Given this list of marker genes Acod1, Adam8, Neu1, C1qb, Myrip, Mmp8, Cd5l, Ms4a6d, Clec4n, Utrn, Fkbp5, Slc37a2 (NCBI Gene Id 56857), Rab7b (NCBI Gene Id 319567), Slc6a2, Cxcl2, Ms4a6c, Mmp19, Pappa, Acp5, C3ar1, Pla2g7, Gpnmb, Lilrb4b, Ccr1, Fcgr2b, Lipf, Cd244a, Dst, Il1r2, Stfa1, Clca3a1, Msr1, Slfn1, Spic, Snx6, C1qc, Mmp12, Ly9 (lymphocyte antigen 9), Fcgr4, Ngp, Fcna, Slc40a1, Atp6v0d2, Ms4a7 (NCBI Gene Id 77229), Xist, Tlr7 (NCBI Gene Id 170743), Sema7a, Cd68, Mafb, Pirb, Rp1, Fcer1g, Mpeg1, Pira1, Fabp7, Mmp13, Cfp, Hmox1 (heme oxygenase 1), Fcgr3, Klrb1b, Clec4e, Slc15a3, Slc11a1, Kif1a, Igsf6, Dnmt3a, S100a9, C1qa, Ctsb, Saa3, Aar2, Tnfaip2, Cd84, Rgs1, Trem2, Camp, Bex1, Amy2a5, Adgre4, Slfn4, Clec4d, Myo5a, Gdf15, Apobec1, Galc, Marco, Steap4, Stfa3, here is a description of the gene set: Mouse Gene Set: LIAN_LIPA_TARGETS_6M from publication Lian X, Yan C, Qin Y, Knox L, Li T, Du H (PMID 16127159) species: Mus musculus The functional roles of neutral lipids in the lung are poorly understood. However, blocking cholesteryl ester and triglyceride metabolism in lysosomal acid lipase gene knockout mice (lal-/-) results in severe pathogenic phenotypes in the lung, including massive neutrophil infiltration, foamy macrophage accumulation, unwanted cell growth, and emphysema. To elucidate the mechanism underlining these pathologies, we performed Affymetrix GeneChip microarray analysis of 1-, 3-, and 6-month-old mice and identified aberrant gene expression that progressed with age. Among changed genes, matrix metalloproteinase (MMP)-12, apoptosis inhibitor 6 (Api-6), erythroblast transformation-specific domain (Ets) transcription factor family member Spi-C, and oncogene MafB were increased 100-, 70-, 40-, and 10-fold, respectively, in lal-/- lungs versus the wild-type lungs. The pathogenic increases of these molecules occurred primarily in alveolar type II epithelial cells. Transcriptional activities of the MMP-12 and Api-6 promoters were stimulated by Spi-C or MafB in respiratory epithelial cells. Treatment with 9-hydroxyoctadecanoic acids and ciglitazone significantly rescued lal-/- pulmonary inflammation and aberrant gene expression. In addition, both compounds as well as peroxisome proliferator-activated receptor gamma inhibited MMP-12 and Api-6 promoter activities. These data suggest that inflammation-triggered cell growth and emphysema during lysosomal acid lipase deficiency are partially caused by peroxisome proliferator-activated receptor-gamma inactivation. Genes up-regulated at 6 months of age in lungs from LIPA knockout mice, which display pulmonary pathology.